The following is a description of a gene set: studied in species Homo sapiens Reactome Pathway: HS-GAG degradation Lysosomal degradation of glycoproteins is part of the cellular homeostasis of glycosylation. The steps outlined below describe the cleavage of heparan sulfate/heparin from heparan sulfate proteoglycans (HSPGs) and its degradation. Complete degradation of glycoproteins is required to avoid build up of glycosaminoglycan fragments which can cause lysosomal storage diseases. The proteolysis of the core protein of the glycoprotein is not shown here. part of: Heparan sulfate/heparin (HS-GAG) metabolism, and this is the list of marker genes: HSPG2, IDS, SDC3, NAGLU, GPC5, HPSE, GPC6, GPC4, HGSNAT, CTSL, SDC4, GPC2, IDUA, GPC1, GPC3, AGRN, SDC1, HPSE2, SDC2, SGSH